The following is a description of a gene set: Mouse Gene Set: GOBP_PROTON_TRANSMEMBRANE_TRANSPORT studied in species Mus musculus The directed movement of a proton across a membrane., and this is the list of marker genes: Atp6ap1, Sting1, Phb2, Il13, Slc45a4, Uqcrh, Ppif, Atp5f1a, Otop1, Slc45a2, Slc18a2, mt-Nd4l, Ndufs8, Slc15a4, Atp1a3, Cox4i2, Slc25a3, Slc25a18, mt-Cytb, Ndufv2, Slc9a6, Letm1, Ndufs4, Ndufs2, Atp6v1b2, Slc9a8 (solute carrier family 9 (sodium/hydrogen exchanger), member 8), Atp4a (ATPase, H+/K+ exchanging, gastric, alpha polypeptide), Sco1, Slc45a1, mt-Atp8, Slc25a4, Slc32a1, Uqcrfs1, Slc9a2 (solute carrier family 9 (sodium/hydrogen exchanger), member 2), Atp6v0d2, Slc47a1, Atp5pf (NCBI Gene Id 11957), Atp6v0e2, Slc17a6, Ucp2, Atp6v0e, Ghitm, Atp5me, Slc45a3, Otop3, Atp6v1h, Otop2, Ndufa4, Asic5, Ndufs7, Slc25a13, Slc9b1, Slc18a3, Cyc1, Slc11a2, Atp5mc3, Atp6v1g2, mt-Co3, Taco1, mt-Nd1, Atp5f1d, Slc46a1, Slc9a1, Atp5f1c, Ndufa2, Ucp3, Slc25a12, Slc25a5, Atp6v0b, Atp6v1b1, mt-Co1 (NCBI Gene Id 99197), mt-Atp6, Ucp1, Atp1b1, Atp7a, Atp5f1b (ATP synthase F1 subunit beta), Atp5mf, Tmco3, Dmac2l, Atp6v1c2, mt-Nd6, Atp5pb, Slc36a3, Atp5mg, Slc25a22, Ndufs1, Slc4a10, Ndufa10, Slc9a9, Atp6ap2, Atp1a1, Ndufb7, Slc25a27, Atp12a (NCBI Gene Id 192113), Atp6v0d1, mt-Nd2, Slc9a3, Slc17a7, Atp6v0a1, mt-Nd3, Sphk2, Slc18b1, Slc9a4, Tmem175, mt-Nd4, Ndufv1, Ctns, Cox17, Slc36a2, Atp6v1g1, Slc16a1, Atp6v0a4, Slc36a1 (solute carrier family 36 (proton/amino acid symporter), member 1), Slc15a2, Atp5po, Atp6v0c (NCBI Gene Id 11984), Atp5pd, Slc15a1, Slc18a1, Atp5f1e, Nr3c2, Atp6v1e2, Fxyd2, Slc25a14, Tcirg1, Atp4b, mt-Nd5, Clcn7, Coa8, mt-Co2, Slc4a11, Slc9a7, Cox7a1, Ndufs3, Hvcn1, Atp6v1c1, Atp6v1d, Slc5a4a, Nnt, Atp6v1f, Rnasek, Atp6v1g3, Slc9a5, Surf1, Il4, Atp1a4 (ATPase, Na+/K+ transporting, alpha 4 polypeptide), Slc9c1, Atp6v0a2, Slc11a1, Slc47a2, Atp1a2, Atp6v1e1, Atp6v1a, Clcn3, Slc9b2, Atp5mc2, Atp5mc1